Given this list of marker genes CENPV, FAM53B, PTP4A1, RAPGEF2, TUBA1A, KCNK5, GFUS, MAN1A1, EFL1, TPCN1 (two pore segment channel 1), POMGNT2, PLXNB2, IRAK1, SH3BGRL2, DIS3L2, TNC, BMP8B, REV3L, SNRK, SMARCA4, MECP2, CD59, COX5A, SLC44A1, NXT1, VPS37B, PRRG4, INTS6L (NCBI Gene Id 654032), RPP25, PNLIPRP1, MICALL1, LINC00880, UPP1, PLS1, PABPC1, NUBP1, CD68, NTNG2, PIP5K1B, DIPK1A, DBNL, FOSL2, ASH1L-AS1, NRN1, DNER, MPC1, RNF139, KATNA1, ATP12A, PRELID3A, GLYCTK, ANKRD27, VHL, PRKCD, MOGAT2, YWHAQ, IDH2, GMPR, CD86, TFEC, SLC31A1, PCTP, EFHD1, MAP3K13, TRMT2A, PABPC3, LGMN, TSPYL4, FBXO7, SLC27A2, MZB1, IRF8, MIR155HG, ODC1, NAPSA, ZBED5-AS1, TRIM47, ISM1, IRAK2, EPS8, RNF4, ME3, RIPK2, MSRB1, HS3ST3A1, L3HYPDH, TMEM164, TENT5A, CKLF, VRK3, PHTF1, KTI12, BTLA, TRAK1, FGF9, FAM53A, RBPJ, OXCT2, PAXIP1, SNN, HYCC1, ZSWIM6, C15orf48, TECR, C3orf52, FBP1, SPATS2L, P2RX5, SLC16A6, CAPN12, SYNGR3, SLC25A4, DENND6B, SERPINB1, G0S2, SERPINB6, ELF4, GIGYF2, POLDIP2, SFMBT1, SOCS2, CD274, SLC37A2, ZNF165, MAP3K5, DNAJB1, ARK2C, FN1, HES6, IFT70B (NCBI Gene Id 150737), MPHOSPH6, AKIRIN1 (NCBI Gene Id 79647), CD93, MAPKAPK3 (MAPK activated protein kinase 3), RFT1, RANBP3, ACSL1, CARD11, LDLRAP1, LAMB3, ZNF76 (zinc finger protein 76), TSPAN2 (tetraspanin 2), BRDT, RGS3, C1GALT1C1, PRDM1, SFXN4, DTNB, EXOSC7, TMX4, STARD8 (NCBI Gene Id 9754), ATG5, SMARCA5, BCAP29, CST3, ADHFE1, CCR10, TRAF3IP3, STS, SDR42E1, PERP, ADGRE5, GNPTG, JUN, ELOVL4, RABAC1, ACAA2, CD14, SNX29, SLC38A6, SYNM, EPAS1 (NCBI Gene Id 2034), RGS9, RNASE6, MAP4K4, OXNAD1, CYP24A1, NDNF, CD38, GADD45A, FBXO41, IL6, SFT2D1, CLRN3, MREG, PMCH, ITGAM, PRPF38A, TCEA2, UQCRB, RTTN (rotatin), MAP3K21, KDM1B, EML6, ABTB3, here is a description of the gene set: In cytotoxic T cells (CTL), Protein Kinase B /Akt is activated by the T cell antigen receptor (TCR) and the cytokine Interleukin 2 (IL2), in part by phosophorylation of Akt by Phospholipid dependent kinase 1 (PDK1). The role of PDK1 and Akt in CTL has however not been fully defined. In order to explore the relative roles of these kinases in CTL we used microarrays to profile the gene expression of control and PDK1 null CTL. In separate experiments we compared the gene expression profiles of control and Akt inhibitor treated CTL. Human Gene Set: GSE26290_WT_VS_PDK1_KO_ANTI_CD3_AND_IL2_STIM_CD8_TCELL_UP Genes up-regulated in cytotoxic T cells: wildtype versus PDK1 knockout. studied in species Homo sapiens from publication Macintyre AN, Finlay D, Preston G, Sinclair LV, Waugh CM, Tamas P, Feijoo C, Okkenhaug K, Cantrell DA (PMID 21295499)